Given this list of marker genes HMGB2, RPA3, H2AZ2, CENPW, PTTG1, SMC4, HMGB3, TUBA1B, MKI67, TYMS, CDKN3, MCM7, TMEM106C, CDK1, DTYMK, TOP2A, ZWINT, CENPF, GGH, UBE2S, CDC20, ARL6IP1, ANP32E, ANLN, HMGN2, KPNA2, H2AZ1, ASPM, TUBA1C, MAD2L1, KIF20B, CCNB1, TK1, H4C3, NUSAP1, CKS2, SMC2, CKAP2, CKS1B, CCNB2 (cyclin B2), RRM2, STMN1, PCLAF (NCBI Gene Id 9768), TPX2, UBE2C, PCNA, BIRC5, UBE2T, TUBB, here is a description of the gene set: Human Gene Set: GAVISH_3CA_METAPROGRAM_FIBROBLASTS_CELL_CYCLE from publication Gavish A, Tyler M, Greenwald AC, Hoefflin R, Simkin D, Tschernichovsky R, Galili Darnell N, Somech E, Barbolin C, Antman T, Kovarsky D, Barrett T, Gonzalez Castro LN, Halder D, Chanoch-Myers R, Laffy J, Mints M, Wider A, Tal R, Spitzer A, Hara T, Raitses-Gurevich M, Stossel C, Golan T, Tirosh A, Suvà ML, Puram SV, Tirosh I (PMID 37258682) In this study, an extensive analysis was conducted to define meta-programs (MPs) capturing intra-tumor heterogeneity across a spectrum of tumor types. The approach utilized non-negative matrix factorization (NMF) to analyze each cell type separately within individual tumor samples. This involved the analysis of malignant cells, macrophages, fibroblasts, endothelial cells, epithelial cells, T-cells, and B-cells. NMF was executed with varying parameter values (K=4, 5, 6, 7, 8, 9), thereby generating 39 programs for each cell type per sample. Each NMF program was summarized by the top genes based on NMF coefficients.\nRobust MPs were then delineated for each cell type using a set of stringent criteria, including recurrence within the same tumor, similarity to programs in other tumors, and non-redundancy within a tumor. Subsequently, these robust NMF programs were clustered (per cell type) based on Jaccard similarity, leading to the identification of MPs associated with each cell type.\nTo enhance the quality of the MPs, a refinement steps were undertaken, involving the removal of MPs suspected of reflecting low-quality data (with an overrepresentation of ribosomal proteins or mitochondrial-encoded genes), single-study inclusion, or similarity to miss-annotated cell types. studied in species Homo sapiens Genes upregulated in subsets of cells of a given type within various tumors